Given this list of marker genes SCAMP5, CYP27A1, PIK3R2, PELI2, TLR8, HSD17B11, ALDH2, H6PD, CIITA, TMEM106B, TIAM1, KCNAB2, TRAPPC12, TRIM47, IGFBP4, NRP1, DIS3L2 (NCBI Gene Id 282696), IKBIP, SLC38A1 (NCBI Gene Id 81539), ANXA9, APPL2, AKAP8L, NDRG3, PRUNE2, RETREG1, BCL2L11, NAXE, KDM6A, CNNM3 (cyclin and CBS domain divalent metal cation transport mediator 3), DHCR7, ULK2, POGLUT3, SPECC1, AP3D1, KIF21B, PEX3 (NCBI Gene Id 8504), CLN6, ACP6, TRERF1, RMND5B, CBR3, ANKLE2, GGA2, INF2, HPGDS, FNBP1, PACC1, PLEKHO1, EXOSC5, CFH, ATF7IP, KHK, DHX34, SCARB2, TMEM41A, UROD, RFC2, EXT2, ADAP2, DUSP19, NCOA1, MDH1, PEPD, CTDSP2, GTPBP8, NFS1, EXOC6, DCXR, LIMA1, TMEM37, ADIPOR1, CCDC34, ADAM10, FBXO31, TRPV2, TMEM109, HMG20A, TMEM143, PXMP4, PTPA, ZCCHC24, SHLD2, STAT6, BCKDHA, NEDD4L, GAB3, SORD, SLC35C2 (solute carrier family 35 member C2), ACOT13, SLC43A2, FAM234A, NFATC1, ACOX3, PCP4L1 (NCBI Gene Id 654790), ATP6AP2, MAVS, KDSR, NBR1, SMPD2, MAN1C1, DECR2, GPR162, H2AZ2, FOXO3, RFC1, TBC1D8, TTC33, PHACTR2, FMO5, AMER1, ACAA2, HDAC5 (histone deacetylase 5), PLXDC1, ADAM8, AKR1B10, N4BP2L1, FAM3C, PSEN2, ASF1B, FAM78A, ING4, NQO2, EI24, KATNB1, CD300C, GLCCI1, HFE, SLC2A3, TBC1D14, RGS2, ATP6V1A, MYO18A, ARHGAP39, FMNL1, SUMO3, FOXO1, NBEAL2, SIPA1, TPM1, SOAT1, GALC, ZSWIM6, LPAR5, PTGR2, CD63, IDUA, MTA3, TPMT, FBXO8, CTNS (NCBI Gene Id 1497), SLC38A9, ALOX5AP, VGLL4, ALDH9A1, ARL4C, LAT2, C6orf62, PIP4K2A, PLEKHM1, HHEX, ADI1, KIFAP3, ENTPD1, ELMO2, SEC14L1, COQ10A, BACH1, IQCE, NRROS, TRIM37, CYB5R1, ZDHHC9, GPR146, GET1, AHNAK, FCGRT, here is a description of the gene set: Borrelia burgdorferi, the agent of Lyme disease, promotes pro-inflammatory changes in endothelium that lead to the recruitment of leukocytes. The host immune response to infection results in increased levels of IFN-gamma in the serum and lesions of Lyme disease patients that correlate with greater severity of disease. Therefore, the effect of IFN-gamma on the gene expression profile of primary human endothelial cells exposed to B. burgdorferi was determined. B. burgdorferi and IFN-gamma synergistically augmented the expression of genes, seven of which encode chemokines. Six of these (CCL7, CCL8, CX3CL1, CXCL9, CXCL10, and CXCL11) attract T lymphocytes, and one (CXCL2) is specific for neutrophils. Synergistic production of the attractants for T cells was confirmed at the protein level. IL-1beta, TNF-alpha, and LPS also cooperated with IFN-gamma to induce synergistic production of CXCL10 by endothelium, indicating that IFN-gamma potentiates inflammation in concert with a variety of mediators. An in vitro model of the blood vessel wall revealed that an increased number of human T lymphocytes traversed endothelium exposed to B. burgdorferi and IFN-gamma, as compared to unstimulated endothelial monolayers. In contrast, addition of IFN-gamma diminished the migration of neutrophils across B. burgdorferi-activated endothelium. IFN-gamma thus alters gene expression by endothelium exposed to B. burgdorferi in a manner that promotes recruitment of T cells and suppresses that of neutrophils. This modulation may facilitate the development of chronic inflammatory lesions in Lyme disease. studied in species Homo sapiens Genes up-regulated in endothelial cells: B. burgdoferi versus IFNG and B. burgdoferi. from publication Dame TM, Orenzoff BL, Palmer LE, Furie MB (PMID 17202382) Human Gene Set: GSE6092_B_BURGDOFERI_VS_B_BURGDORFERI_AND_IFNG_STIM_ENDOTHELIAL_CELL_UP